Given this list of marker genes Usp27x, Micu1, Krtap5-4, Pnck, Pdzd8, Fdft1, Adrb3, Trp53inp1, Gpr82, Plp2, Ankrd45, Hic2, Zfp2, Cts8, Gm12185, Aspm, Adam23, Chd1, Zfp174, Cpsf7, Vstm2b, Osm, Srsf1, Septin1, Ints4, Ndufa7, Card11, Cgnl1, Tmem144, Supt5, Nav1, Cyp2b13, Ranbp10, Leng8, Smyd3, Zfp106, Gtpbp1, Naa50 (N(alpha)-acetyltransferase 50, NatE catalytic subunit), Nucks1, Ppp1r1c, Clec3a, Pakap, Zic4, Nova2, Man1a2, Poldip3, Matn1, Barhl1, Rasal2, Eppk1, Nppc, Ilf3, Stc2, B3gnt6, Lamc2, Timp1, Atp6v1e1, Erv3, Igdcc4, Ptchd1, Scd1, Vsig1, Nrm (nurim (nuclear envelope membrane protein)), Scamp2, D630045J12Rik, Elmo1 (NCBI Gene Id 320830), Zfp575, Agpat1, Ocrl, Dock5, Usb1, Sbk3, Sypl2, Ahsa2, Ccdc122, Rbm24, Cacna2d1, Pate2, Mcu, Txnrd1, Lurap1, Avl9, Kdm5a, Smad7, Lrrc59, Mgat5b, Rcor1, Ltb4r2, Cdh17, Fam131a, 1110004F10Rik, E2f3, Exph5, Ino80 (INO80 complex subunit), D430019H16Rik, Ltbp1, Entpd7, Csnk1g1, Vps26b, Gan, Pip4p1, Mbnl3, Retreg3, Camk1d, Cdc42ep4, Trim35, Slc25a45, Frmd7, Atf7, Prkce, Clvs1, Eef2k, Sec22c, Kpna3, Tmed7, Pea15a, Fxr1, Arid2, Dcc, Grik1, Ssbp3, Vamp2, Limd1, Tifab, Ephb4, Tiam1, Pofut2, Calm2 (calmodulin 2), Glis2, Serpinb5, Card10, Tom1, Sesn1, Aif1l, St6galnac6, C1qc, Ttc27, Supt16, Mtcl2, Mybpc1, Shisa6, Zfp286, Fbxw7, Agap1, Rab6b, Baalc, Maml1, Arpc2, Zc4h2, Mlph, Kcnj6, Opa3, Pm20d1, Wasf1, Stard5, Prelp, Tmem233, Samd4, Otud7b, Dnajc13, Hsd17b7 (hydroxysteroid (17-beta) dehydrogenase 7), Fhip2a, Tnrc6a, Utp11, here is a description of the gene set: from publication Chen Y, Wang X (PMID 31504780) Genes predicted to be targets of miRBase v22 microRNA mmu_miR_8100 in miRDB v6.0 with MirTarget v4 prediction scores > 80 (high confidence targets). studied in species Mus musculus Mouse Gene Set: MIR_8100